The following is a description of a gene set: Abnormal morphology of the abdominal musculature An abnormality of the abdominal musculature. studied in species Homo sapiens Human Gene Set: HP_ABNORMAL_MORPHOLOGY_OF_THE_ABDOMINAL_MUSCULATURE, and this is the list of marker genes: RRAS, MANBA, ACTG2, H19, CDKN1C, CBL, SHPK, KCNQ1OT1, EZH2, B3GLCT, MYH3, DIS3L2, SPRED2, SLC25A24, MEG3, COLEC10 (collectin subfamily member 10), GUSB, CHST14, MRAS, DLK1, CANT1, RAF1 (NCBI Gene Id 5894), COL3A1, CSGALNACT1, FLNB, PPP2R3C, MTOR, PTPN11, TBCK, GPC3, COLEC11, CHRM3, GPC4 (NCBI Gene Id 2239), PIGQ, KCNQ1, MCOLN1, CD96, RRAS2, FBN1, GNPTAB, SOS2, RIT1, ATP7A, SOS1, CHAMP1, XYLT1, RTL1, RMRP, ELMO2, SOX6, IGF2, KRAS, LZTR1, FOXF1, NRAS, SKI, MASP1, RASA2, CHRNG, BRAF, PORCN